Given this list of marker genes Pdgfrb, Gstp1 (glutathione S-transferase, pi 1), Mdk, Nrp1, Gstp2, Aif1, Slit2, Coro1b, Lpar1, Pdgfd, Parva, here is a description of the gene set: The directed movement of a smooth muscle cell in response to an external stimulus. Mouse Gene Set: GOBP_SMOOTH_MUSCLE_CELL_CHEMOTAXIS species: Mus musculus